The following is a description of a gene set: Human Gene Set: GOBP_CXCL12_ACTIVATED_CXCR4_SIGNALING_PATHWAY The series of molecular signals initiated by the binding of the C-X-C chemokine CXCL12 to a C-X-C chemokine type 4 receptor (CXCR4) on the surface of a target cell, and ending with the regulation of a downstream cellular process, e.g. transcription. studied in species Homo sapiens, and this is the list of marker genes: CXCR4, TREM2, CXCL12, ENTREP1, WBP1L